Given this list of marker genes PTGDS, ALOX15B, CYP2J2, PRXL2B, PON3, PTGIS, CYP1B1, TBXAS1, CYP1A2, GPX2, LTC4S, CYP4F3, SLC27A1, CYP4A22, ALOX5, PTGS1, ALOX5AP, CYP2U1, EPHX2, GPX1, DPEP2, PTGES2, FAAH2, AKR1C3, PTGS2, LTA4H, ABCC1, GPX4, CYP2C19, CYP4A11, CYP2C9, GGT1, CBR1 (carbonyl reductase 1), PON2, PON1, FAAH, CYP4F8, HPGDS (hematopoietic prostaglandin D synthase), PTGR1, PTGES (NCBI Gene Id 9536), PLA2G4A, ALOXE3, CYP4F22, CYP4F2, PTGR2, HPGD, CYP1A1, PTGES3, ALOX12B, CYP4F11, AWAT1, ALOX15, DPEP1, CYP8B1, GGT5, MAPKAPK2, CYP2C8, ALOX12, CYP4B1, here is a description of the gene set: Reactome Pathway: Arachidonate metabolism Eicosanoids, oxygenated, 20-carbon fatty acids, are autocrine and paracrine signaling molecules that modulate physiological processes including pain, fever, inflammation, blood clot formation, smooth muscle contraction and relaxation, and the release of gastric acid. Eicosanoids are synthesized in humans primarily from arachidonate (all-cis 5,8,11,14-eicosatetraenoate) that is released from membrane phospholipids. Once released, arachidonate is acted on by prostaglandin G/H synthases (PTGS, also known as cyclooxygenases (COX)) to form prostaglandins and thromboxanes, by arachidonate lipoxygenases (ALOX) to form leukotrienes, epoxygenases (cytochrome P450s and epoxide hydrolase) to form epoxides such as 15-eicosatetraenoic acids, and omega-hydrolases (cytochrome P450s) to form hydroxyeicosatetraenoates.<br>Levels of free arachidonate in the cell are normally very low so the rate of synthesis of eicosanoids is determined primarily by the activity of phospholipase A2, which mediates phospholipid cleavage to generate free arachidonate. The enzymes involved in arachidonate metabolism are typically constitutively expressed so the subset of these enzymes expressed by a cell determines the range of eicosanoids it can synthesize.<br>Eicosanoids are unstable, undergoing conversion to inactive forms with half-times under physiological conditions of seconds or minutes. Many of these reactions appear to be spontaneous. species: Homo sapiens part of: Fatty acid metabolism